The following is a description of a gene set: Mouse Gene Set: GOBP_POSITIVE_REGULATION_OF_GAMMA_AMINOBUTYRIC_ACID_SECRETION Any process that activates or increases the frequency, rate or extent of the regulated release of gamma-aminobutyric acid. studied in species Mus musculus, and this is the list of marker genes: Htr2c, Htr6, Trh, Grik1, Slc6a1, P2rx7, Ntsr1